Given this list of marker genes ELF4, CDC42EP3, LYSET, HNRNPA0, NAB1, RBM14, EIF4G2, MAP3K14, ARF1, NFYA, UCHL3, FKBP2, PLPP1, UBE2D1, VDAC3, HPS5, IFRD1, RGS10, RRAS2, SRGN, MAP2K3, ZNF195, SLC5A3, ADO, GNG5, ZNF271P, COX17, SEC62, RANBP2, PSMD14, CLIC1, NOL7, CSTB, GEM, CASP10, GNL2, WNK1, UTP14C, KLRG1, PTPN22, MKLN1, EEF1E1, AFAP1, FANCI (FA complementation group I), RPA3, LCP2 (NCBI Gene Id 3937), FEN1, CYCS, EGR3, S1PR1, TRAPPC2B, IL1RAP, ANKRD40, PER2, EZR, LRRFIP1, GTF2E2, URB2, RIPK2, AHR (NCBI Gene Id 196), AGO2, PNP, PPP2CA, AHCYL1, PAQR3, TEX30, TFAM, STX1A, SACS, ANKLE2, HBEGF, ARFGAP3, TRAF1 (TNF receptor associated factor 1), ACSL1, RAB22A, SUCLA2, PRDX3, TNFRSF1B, WDR1, EIF2S1, SNRPG, EZH2, IL18RAP, FAM98A, TOX4, LIG4, SPRY1, RPGR, CYTIP, PLAGL2, CA2, ATF3 (NCBI Gene Id 467), SNAPC5, AP3M2, CCL4, DAAM1, ATP6V1A, SH2D2A, JRKL, SERPINE2, PALLD, PSMB5, CD47, CTSL, CHMP2A (charged multivesicular body protein 2A), SPON1, NELFE, IVNS1ABP, UTP3, TUBB4B, HNRNPAB (NCBI Gene Id 3182), CD200 (NCBI Gene Id 4345), UMPS, GNAI1, KLHL9, KIFBP, TRPC6, BCL2L11, MAP3K11, PRPF18, IPO7, CD58, ATP2B1, ZNF140, IMPA1, BCL2A1, PNO1, PSMD1, ZPR1, C1orf216, CD81, NFE2L2, ACTG1, DUSP5, SP3, GFI1, BAZ2B, FADD, UAP1, DYNLL1, ICOS, PSMD7 (proteasome 26S subunit, non-ATPase 7), WDR47, DIMT1, TUBB2A, IL18R1, SYNCRIP, CD40LG, CCDC6, RRS1, SS18L1, PGGT1B, ZNF165, CFLAR, NDEL1, CCT5, CHSY1 (NCBI Gene Id 22856), RHOG, IL4R, PSMD9, GABPA (GA binding protein transcription factor subunit alpha), EIF4E, NFKB1, HSBP1, MPHOSPH10, NECTIN3, TXNDC9, TXLNA, PAICS, NCBP2, MBNL1, TMEM243, MTHFD2, PGAP1, HNRNPF, RAD1 (RAD1 checkpoint DNA exonuclease), GABPB1, EMG1, FEZ2, POGZ, YWHAE, ATP1B3, SLC7A5, EGR2, IL2, STK4, PPRC1, NPC1, ATP6V0A2, SLC25A16, NUP160, ACP2, SAFB2, PGAM1, PEX3, IER3, BCL9, GTF2H1, PLP2, LPCAT1, here is a description of the gene set: Genes down-regulated in NKT cells: naïve versus activated. Microarray analysis was performed to determine the transcriptional profiles of NKT, CD1d-aGC+ Va24-, and CD4 T cells. species: Homo sapiens Human Gene Set: GSE28726_NAIVE_VS_ACTIVATED_NKTCELL_DN from publication Constantinides MG, Picard D, Savage AK, Bendelac A (PMID 21632718)